Given this list of marker genes NPPB, CHGA, HNF1A, DRD2, LINC01138, CHGB, NHLH2 (NCBI Gene Id 90888), CRH, CSMD3, PTH1R, GLRA3, SLC12A5, GPRIN1, FGD2, INA (internexin neuronal intermediate filament protein alpha), DRD3, NEFH, TMEM179, PFN1 (profilin 1), L1CAM, BDNF, MAPK11, PGF, HHATL, NEFM, ZWILCH, HPCA, JMJD1C, SLC17A6, ELAVL3, CELF3, CCL21, TLCD3B, BEX1, SIGIRR, SYT6, LHX3, DNER, COL5A3, PTPRN, OMG, DPH2, LINC02363, CDK5R1, GRIN1, MYF5, PAQR4, SLC35G2, BRINP1, SYT4, GABRG2, GPATCH11 (G-patch domain containing 11), TSPAN33, OGDHL, ZNF654, SLC25A28, TNFRSF19, KCNH4, ANKZF1, ATG9A (autophagy related 9A), KCNIP2, SCN3B, RPH3A, MYL10, PLAC1, AOC2, WAS, PRG3, CALB1, SCHIP1, GSE1, GRM1, PRMT3, MIR9-1HG, PHYHIPL, RPL4, SARM1, HTR1A, FOXN3, POU4F3, MGAT5B, BARHL1, CHRNB2, CACNA1B, PAFAH1B1, VIP, CHAT, CHKA, here is a description of the gene set: Human Gene Set: CAGNWMCNNNGAC_UNKNOWN Genes having at least one occurrence of the highly conserved motif M143 CAGNWMCNNNGAC in the regions spanning 4 kb centered on their transcription starting sites. The motif does not match any known transcription factor binding site. from publication Xie X, Lu J, Kulbokas EJ, Golub TR, Mootha V, Lindblad-Toh K, Lander ES, Kellis M (PMID 15735639) Comprehensive identification of all functional elements encoded in the human genome is a fundamental need in biomedical research. Here, we present a comparative analysis of the human, mouse, rat and dog genomes to create a systematic catalogue of common regulatory motifs in promoters and 3' untranslated regions (3' UTRs). The promoter analysis yields 174 candidate motifs, including most previously known transcription-factor binding sites and 105 new motifs. The 3'-UTR analysis yields 106 motifs likely to be involved in post-transcriptional regulation. Nearly one-half are associated with microRNAs (miRNAs), leading to the discovery of many new miRNA genes and their likely target genes. Our results suggest that previous estimates of the number of human miRNA genes were low, and that miRNAs regulate at least 20% of human genes. The overall results provide a systematic view of gene regulation in the human, which will be refined as additional mammalian genomes become available. studied in species Homo sapiens